Given this list of marker genes CEP290, SOX9, FGFR2, SIX1, COL2A1, EYA1, AHI1, PROX1, TCAP, FGF10, GET1, PAX8, GATA3, STOX1, HESX1, FGF8, here is a description of the gene set: The process whose specific outcome is the progression of the otic vesicle over time, from its formation to the mature structure. The otic vesicle is a transient embryonic structure formed during development of the vertebrate inner ear. Human Gene Set: GOBP_OTIC_VESICLE_DEVELOPMENT species: Homo sapiens